The following is a description of a gene set: species: Homo sapiens Human Gene Set: WP_COMPLEMENT_AND_COAGULATION_CASCADES Complement and coagulation cascades, and this is the list of marker genes: TFPI (tissue factor pathway inhibitor), MASP2, F7, F9, F13B, C1R, SERPINA5, C1QA, CFI, F5, CLTC, PLAUR, C4B, F12, F8 (NCBI Gene Id 14069), C7, C8G, C1QC, CD46, CD55, SERPIND1, SERPINE1, CR1, CFB, PLAT, SERPINF2, C3, BDKRB1, VWF, F10 (NCBI Gene Id 14058), LMAN1, PROS1, CR2, CFH, F2R, MASP1, C9, CFD, SERPINA1, KLKB1, PLAU, C3AR1, CPB2, CLU, C5AR1, FGB, PROC, PLG, SERPING1, C1S, SERPINC1, F2, C2, C6 (complement component 6), THBD (thrombomodulin), F3, KNG1, C1QB